The following is a description of a gene set: Human Gene Set: NAKAYA_MONOCYTE_FLUMIST_AGE_18_50YO_7DY_DN Genes down-regulated in monocyte 7d vs 0d in young adults (18-50) after exposure to FluMist, time point 7D Here we have used a systems biology approach to study innate and adaptive responses to vaccination against influenza in humans during three consecutive influenza seasons. We studied healthy adults vaccinated with trivalent inactivated influenza vaccine (TIV) or live attenuated influenza vaccine (LAIV). TIV induced higher antibody titers and more plasmablasts than LAIV did. In subjects vaccinated with TIV, early molecular signatures correlated with and could be used to accurately predict later antibody titers in two independent trials. Notably, expression of the kinase CaMKIV at day 3 was inversely correlated with later antibody titers. Vaccination of CaMKIV-deficient mice with TIV induced enhanced antigen-specific antibody titers, which demonstrated an unappreciated role for CaMKIV in the regulation of antibody responses. Thus, systems approaches can be used to predict immunogenicity and provide new mechanistic insights about vaccines. from publication Nakaya HI, Wrammert J, Lee EK, Racioppi L, Marie-Kunze S, Haining WN, Means AR, Kasturi SP, Khan N, Li GM, McCausland M, Kanchan V, Kokko KE, Li S, Elbein R, Mehta AK, Aderem A, Subbarao K, Ahmed R, Pulendran B (PMID 21743478) studied in species Homo sapiens, and this is the list of marker genes: ID2B, HCFC1R1, UBTF, ENPP4, PLXNB2, HIF1A, DSC2, FOSL2, BNIP1, TFPT, PPM1A, IQSEC1, RECQL5, EBLN2, IL1RN, PHLPP2, SAMSN1, ZW10, ELL, SNIP1, COG7, COPB1, GLYR1, EIF4G1, CDH16, ELF4, CTBP1, EPHB1, MAP3K14, BIN1, CLN8, RAC2, MPZL1, TFIP11, PDZK1IP1, TWF1, C2CD3, GSTM1 (glutathione S-transferase mu 1), SMURF2, LY6E, VAMP5, MTOR, RAD1, GOSR1, PHLDA1, GK, FUT4, RAP2B, AMMECR1, FLNB (NCBI Gene Id 8413), GLS (glutaminase), NBN, TCL1A, MBTPS2, HYMAI, NXN, TSR3, TMPRSS15, AMELY, ZBTB43, PHACTR1, PLAGL2, DIO2, GNA13, PLEK, PRNP, CHN2, HBP1, ACTL7A, ZBTB7B, SIRPA, GGTLC2 (NCBI Gene Id 91227), RAB2A, GALNT10, CBX6, UROD, NFATC1, TNNI2, IFT122, TSPYL2, RNF6, IGKC, LPIN2 (NCBI Gene Id 9663), NACA, MGLL, ZNF394, ANAPC5, CD84, THBS1, TGFB1, SPDEF, LILRA3, AGER, DIAPH1, SLC29A1, STK38, BARD1, PLSCR3, TPM3, MBP, SLC22A4, LY6G5C, HBEGF, CD247, TMEM158, DDX49, AKAP13, FLOT1, UBAP1, RNF126, TMCC2, R3HCC1, ZNF267, RUNX1, SMARCD1, FBXO3, IRF7, THBD, FAM3A, MCM3AP, PLAAT3, MLEC, SLC25A37, BHLHE40, PIK3CB, JAK3, DDIT4, CSF1, KAZN, NUP50, CHD2, RSRC1 (NCBI Gene Id 51319), SZT2, ADCK2 (aarF domain containing kinase 2), TENT5A, UTP18, KDM6B, SPTBN5, ATOSB, PFKFB3, ATP4A, GM2A, MYO1A, RHOC, PIK3CG, IGFBP5, MAL, PML, ADORA3, EMP1, MTHFR, MAP1A, ERAP1, ZNF3, HES1, SLC6A6, OASL, SMIM7, TPPP3, APOA2, SEPTIN6, NUMA1 (NCBI Gene Id 4926), SKIL, VSIG4, CYLD, REL, NFKBIE, GPX3, RUNX2, IRF4, TIGAR, CALR, FUT7, RASSF7, LAMP5, EPHB2, XPNPEP1, IGFALS, SOCS3, PDK2, NET1, TAPBPL, INVS, COG5, PXMP4, ARL4C, PPFIBP2, PLEKHO2, YES1, YOD1, CIT, ZDHHC17, RAP2A, CHD1, OTUB1, MARCHF6, DOK1, APLP2, COL1A1, MACF1, TRAPPC4, CLP1, SMAD3, GALNT3, TLE3, DHRS3, CD209, SEC14L1, PLXNA1, SIRT7, PDE4D, BRPF1, PLN, JRK, PAFAH1B2, SLC35D1, RNF185, ZRSR2P1, FTSJ1, MTMR9, TNFAIP2, CCDC186, SH3BP2, ZNF589, LDLR, CROCCP3, RAB20, STK32B, RREB1, MTF2, SEC14L5, PHF1, FAXDC2, MAPKAPK2, ID2, LMNA, MEF2D, GMEB1, HLA-DOB, NLRP1, SRSF11, TYRO3 (NCBI Gene Id 7301), KRAS, ARF6, ATP2B1, PRPS1, KLHL26, AHCTF1, ACOT7, ITCH, RPH3AL, SMAD7, C1QA, POLR2A, PIGZ, ZGPAT, BTN2A1, EHD1, VEGFA, ESR2